The following is a description of a gene set: studied in species Mus musculus Mouse Gene Set: REACTOME_PCP_CE_PATHWAY PCP/CE pathway, and this is the list of marker genes: Wnt5a, Ap2b1, Ap2a2, Uba52rt, Wnt4, Fzd4, Ror1, Adrm1, Psma3, Psmd8, Uba52, Psmc1, Fzd7, Psmd1, Wnt5b, Ap2m1, Fzd1, Psma5, Arrb2, Prkcg, Ubc, Psmc5, Wnt11, Psmd11, Dvl3, Psma2, Rac3, Psmb5, Rac2, Psmd12, Wnt1, Pfn1, Rac1, Psmd14, Psmd7, Daam1 (NCBI Gene Id 69600), Dvl2, Psmc2, Fzd6 (frizzled class receptor 6), Psmb6, Psma7, Psmb4, Pard6a, Psmb7, Ubb, Psma6, Fzd2, Fzd8, Psmd13, Psmd3, Clta, Cltb, Psma1, Fzd3, Smurf1, Prickle1, Psmb3, Ap2a1, Psmc3, Ap2s1, Psmb2, Psmd6, Psmb1, Psmc4, Psmd2, Rps27a, Cltc, Prkcb, Psmc6, Fzd5, Rhoa, Smurf2, Psma4, Dvl1